The following is a description of a gene set: GHRHR-PKA-GH signaling pathway. Pathway ID: N00910. Pathway type: Reference. Pathway class: nt06324 GHRH-GH-IGF signaling. Pathway Definition from KEGG: GHRH -> GHRHR -> GNAS -> ADCY -> cAMP -> PKA -> CREB => POU1F1 => (GH1,GH2) studied in species Homo sapiens Human Gene Set: KEGG_MEDICUS_REFERENCE_GHRHR_PKA_GH_SIGNALING_PATHWAY, and this is the list of marker genes: GH2, CREB3L4 (NCBI Gene Id 338028), GHRHR, CREB3L1, ADCY9, CREB3L2, ADCY3, ADCY8, GNAS, ATF6B, ADCY5, CREB5, GHRH, ADCY6, ATF4, GH1, PRKACB, CREB3L3, ADCY7, PRKACG, POU1F1, CREB3, CREB1, ATF2, ADCY4, ADCY1, ADCY2 (adenylate cyclase 2), PRKACA